Given this list of marker genes ITGA8, RET, SIX1, ANOS1, GDF11, ETV4, HOXD11, FST, SHH, CTDNEP1, SIX2, CRIM1, RARB, SALL1, BMPER, TGFB1, GFRA1, FREM1, ETV5, SMAD1, RARG, VANGL2, HOXA11, CELSR1, FRAS1, SMO, GLI3, BMPR2, BMP4 (NCBI Gene Id 652), GLI2 (NCBI Gene Id 50806), GLI1, GPC3, BMP5, GRIP1, TGFB2, MYCN, PAX2, GDNF, WNT11, SPRY1, BMP7, FREM2, RARA, BMP2, CCND1, DCN, BMPR1A, EYA1, here is a description of the gene set: studied in species Homo sapiens Development of ureteric derived collecting system Human Gene Set: WP_DEVELOPMENT_OF_URETERIC_DERIVED_COLLECTING_SYSTEM